Given this list of marker genes VAX1, PNPLA2, NONO, RNU4-2, KRAS, ADNP, DKC1, PSMD12, KANSL1, BPTF, WDR26, GALNT2, INSR, here is a description of the gene set: Human Gene Set: HP_ABNORMAL_PINEAL_MORPHOLOGY A structural abnormality of the pineal gland. species: Homo sapiens Abnormal pineal morphology